Given this list of marker genes Pi4k2a, Pik3r4, Ocrl, Vac14, Fig4, Inpp5e, Sacm1l, Pik3c2g, Pikfyve, Pi4kb, Pi4k2b, Tpte, Arf3, Pi4ka, Pik3c2a, Arf1, Pik3c3, here is a description of the gene set: Mouse Gene Set: REACTOME_SYNTHESIS_OF_PIPS_AT_THE_GOLGI_MEMBRANE Synthesis of PIPs at the Golgi membrane species: Mus musculus